The following is a description of a gene set: Genes predicted to be targets of miRBase v22 microRNA mmu_miR_6980_3p in miRDB v6.0 with MirTarget v4 prediction scores > 80 (high confidence targets). from publication Chen Y, Wang X (PMID 31504780) Mouse Gene Set: MIR_6980_3P studied in species Mus musculus, and this is the list of marker genes: Nrg3, Ccna2, Kcnma1, Traf3ip2, Megf11, Dab2ip, Zbtb43, Zcchc24, Nfasc, Ephx3, AI597479, Slc17a6, Cplx4, Nckap5, Ippk, Rusc1, Disp3, Ubxn7, Zfp825, Ppargc1a, Marchf5, Slc7a11, Klhdc10, Hsd3b5, Itga6, Fst, Csn2, Phactr3, Slc35f1, Anxa1, Il5ra, Zfp65, Pdk3, Cpne3, Pcdh15, Morf4l1, Hrh4, Ube2e3, Dmd, Dtd2, Mical3, Pptc7, Kif5b, Larp4, Kcna6, Arid4b, Bpifb2, Tnrc6b, Scmh1